Given this list of marker genes Sema4c, Epha7, Sema4f, Sema4b, Sema4a, Sema4d, Sema3c, Nrg3, Wnt5a, Itgb3, Unc5c, Slit3, Sema7a, Sema3b, Itgav, Nrg1, Slit1, Robo1, Flrt3, Sema3g, Pdgfa, Flrt2, Igfals (insulin-like growth factor binding protein, acid labile subunit), Sema3e (sema domain, immunoglobulin domain (Ig), short basic domain, secreted, (semaphorin) 3E), Robo2, Sema3a, Ryk, Apoa1, Ntn1, Sema4g, Plxna4, Rtn4r, Sema3f, Plxna3, Rhoa, Nrp2, Lgr4, Dpp4, Sema3d, Slit2, Efna5, Rtn4rl1, here is a description of the gene set: The directed movement of a motile cell or organism towards a lower concentration of a chemical. studied in species Mus musculus Mouse Gene Set: GOBP_NEGATIVE_CHEMOTAXIS